Given this list of marker genes MAPRE3, GNAI2, EIF4A1 (eukaryotic translation initiation factor 4A1), TBC1D2B, MINK1, GPS2 (NCBI Gene Id 2874), VDAC1, GEMIN4, PRDX4, ZZEF1, TP53, ASMTL, RYR1, GLOD4, TNPO3, SCP2, RRAS2, FXR2, PLD2, HNRNPDL, GABARAP, SENP3, here is a description of the gene set: species: Homo sapiens Human Gene Set: HASLINGER_B_CLL_WITH_17P13_DELETION from publication Haslinger C, Schweifer N, Stilgenbauer S, Döhner H, Lichter P, Kraut N, Stratowa C, Abseher R (PMID 15459216) PURPOSE: Genomic aberrations and mutational status of the immunoglobulin variable heavy chain (VH) gene have been shown to be among the most important predictors for outcome in patients with B-cell chronic lymphocytic leukemia (B-CLL). In this study, we report on differential gene expression patterns that are characteristic for genetically defined B-CLL subtypes. MATERIALS AND METHODS: One hundred genetically well-characterized B-CLL samples, together with 11 healthy control samples, were analyzed using oligonucleotide arrays, which test for the expression of some 12,000 human genes. RESULTS: Aiming at microarray-based subclassification, class predictors were constructed using sets of differentially expressed genes, which yielded in zero or low misclassification rates. Furthermore, a significant number of the differentially expressed genes clustered in chromosomal regions affected by the respective genomic losses/gains. Deletions affecting chromosome bands 11q22-q23 and 17p13 led to a reduced expression of the corresponding genes, such as ATM and p53, while trisomy 12 resulted in the upregulation of genes mapping to chromosome arm 12q. Using an unsupervised analysis algorithm, expression profiling allowed partitioning into predominantly VH-mutated versus unmutated patient groups; however, association of the expression profile with the VH mutational status could only be detected in male patients. CONCLUSION: The finding that the most significantly differentially expressed genes are located in the corresponding aberrant chromosomal regions indicates that a gene dosage effect may exert a pathogenic role in B-CLL. The significant difference in the partitioning of male and female B-CLL samples suggests that the genomic signature for the VH mutational status might be sex-related. Genes changed in the B cell chronic lymphocytic leukemia (B-CLL) with deletions in the 17p13 region.